Given this list of marker genes ARMC3, GRB7, RBP2, INSYN2A, CDT1, RRN3, SOSTDC1, EFCAB3, MEGF6, CLDN8, DEFA5, RDH16, AZGP1P1, FRMD1, EQTN (equatorin), SPAG4, ODAM, DAPL1, NHLH2, PTPRB, PRAP1, INSL5, CASC16, WDR97, DCDC2, OTOF, DNAH1, IL4, MCTP2, MT1M, KRT80, ANKRD30BP2, KIF19, KRT32, GEM, PRKCZ (NCBI Gene Id 5590), STK32B, CHRD, SOX1, AVPR2, CST1 (cystatin SN), DLG1-AS1, SCAMP5, CLDN4, NRXN3, AGBL4, TXK, RIBC2, KICS2, ZC3H12C, GLRA1, IMPG1, C19orf81, PARD6G, PPDPFL, AQP10, HSD17B2, HTR5A, OPRL1, ARC, BTNL2, GPM6B, PPFIA4, IHH, FOXF2, SLC23A1, SCGB1A1, PLCD4, ZNF800 (NCBI Gene Id 168850), C15orf32, ZNF653, PCDH9, MTPN, LINC02139, PLB1, ARHGAP39, IL22 (NCBI Gene Id 57328, interleukin 22), PHYHD1, RAC3, PDZD7, VMO1, CPLANE1, CXCL11, MORN4, BCO2, MORC1, ABLIM3, LCAL1, KLF3-AS1, ABCC2, BMP10, TMC2, ZNF507, GPR22, CAMK2A, C11orf52, KLLN, CXorf51A, CYP4A11, FER1L6-AS1, KRBOX1, GP1BB, ENSG00000293232, KLK5, PAK5, IL2RB, WASF1, SLC6A1, IDO2, RERG, CHIA, ART4, DSCR9 (NCBI Gene Id 257203), CUBN, EYS, TEX22, KRT83, PCDHGB8P, AP1G2 (NCBI Gene Id 8906), NDRG4, HRK, CRYGN, ZNF365, PICART1, KRTAP4-1 (NCBI Gene Id 85292), RSPH10B2, LINC00641, CNTFR-AS1, ATCAY, NPY1R, EGFLAM, KRT77, POGLUT2, KLHL14, ANKRD17, CYP11B1, CRHR1, OR7E14P, GRAMD1C, SPTA1, REN, ANKFN1, MBD3L1, ADH1B, PALM, CLTCL1 (clathrin heavy chain like 1), ADAM20, SLC13A2, HSD3B1, ABCG5, SELP (selectin P), SPINK7, ELOVL7, AGL, OSER1-DT, SPAG9, FCGR1BP, LRRC2-AS1, RIPPLY1, NKX6-1, KCNK12, ZRSR2P1, LINC00310, INTU, NR6A1, DIRC3, INHBC, CHL1-AS2, NR1I2, PDZRN3, CPLX2, ENSG00000230725, LINC00622, RBPMS, CCDC81, H1-10-AS1, LINC03018, DIRAS2, PIM3, OR6B1, RAB40AL, TNP1, KRTAP10-12, WT1, LINC01116, MIR124-2HG, TAS1R1, SCGB2A1, MYL11, here is a description of the gene set: During acute viral infections, naïve CD8+ T cells differentiate into effector CD8+ T cells and, after viral control, into memory CD8+ T cells. Memory CD8+ T cells are highly functional, proliferate rapidly upon reinfection and persist long-term without antigen. In contrast, during chronic infections, CD8+ T cells become “exhausted” and have poor effector function, express multiple inhibitory receptors, possess low proliferative capacity, and cannot persist without antigen. To compare the development of functional memory T cells with poorly functional exhausted T cells, we generated longitudinal transcriptional profiles for each. studied in species Homo sapiens Genes up-regulated in CD8 T effector cells during chronic infection with LCMV-Clone 13: day 6 versus day 15. from publication Doering TA, Crawford A, Angelosanto JM, Paley MA, Ziegler CG, Wherry EJ (PMID 23159438) Human Gene Set: GSE41867_DAY6_VS_DAY15_LCMV_CLONE13_EFFECTOR_CD8_TCELL_UP